The following is a description of a gene set: studied in species Homo sapiens Pathway Definition from KEGG: FN1 -> (ITGA+ITGB) -> PTK2 -> ARHGEF28 -> RHOA ITGA/B-RhoGEF-RhoA signaling pathway. Pathway ID: N01072. Pathway type: Reference. Pathway class: nt06135 Cytoskeletal regulation (viruses and bacteria). Human Gene Set: KEGG_MEDICUS_REFERENCE_ITGA_B_RHOGEF_RHOA_SIGNALING_PATHWAY, and this is the list of marker genes: FN1, ITGA1, ITGB6, ITGB4, ITGB7, ITGB3 (NCBI Gene Id 3690), ITGA2, RHOA, ITGA8, ITGA3, ITGA7, ITGA9, ITGB1, ITGA10, ARHGEF28, ITGA4, ITGAV, PTK2, ITGB5, ITGA2B, ITGB8, ITGA11, ITGA5